The following is a description of a gene set: studied in species Homo sapiens Human Gene Set: chr7p12, and this is the list of marker genes: UPP1, IGFBP3, LINC01446, RNU6-1091P, ENSG00000253028 (NCBI Gene Id 124900240), LINC02902, LINC01447, SUN3, HMGN1P19, C7orf57, SGO1P2, ENSG00000230680, GRB10, RNU6-326P, GTF2IP13, ZPBP, RNF138P2, PKD1L1, HAUS6P3, ROBO2P1, RN7SL292P, IGFBP1, TNS3, ENSG00000286658, GNL2P1, CCDC201, RN7SKP218, RNU2-29P, ENSG00000286315, POM121L12 (NCBI Gene Id 285877), CICP20, DDC, TTC4P1, GDI2P1, DDX43P2, PKD1L1-AS1, ENSG00000201133, SRSF8CP, LINC02838, DDC-AS1, SPMIP7, RAC1P9, HUS1, ENSG00000237471, LINC00525, FTLP15, CDC14C, ABCA13, MRPL42P4, RNU1-14P, ENSG00000233539, RNU6-241P, HAUS6P1, IKZF1, CICP17, ENSG00000309876, RRBP1P1, FIGNL1, ADCY1, EPS15P1, RPL7L1P2, VWC2, ZNF619P1, SEPTIN7P2, COBL, ENSG00000229192